The following is a description of a gene set: Mouse Gene Set: REACTOME_NEGATIVE_REGULATION_OF_ACTIVITY_OF_TFAP2_AP_2_FAMILY_TRANSCRIPTION_FACTORS Negative regulation of activity of TFAP2 (AP-2) family transcription factors species: Mus musculus, and this is the list of marker genes: Tfap2c, Sumo1, Tfap2a, Wwox, Tfap2e, Tfap2b, Kctd1, Ube2i, Tfap2d